The following is a description of a gene set: from publication Chen Y, Wang X (PMID 31504780) Mouse Gene Set: MIR_1955_3P studied in species Mus musculus Genes predicted to be targets of miRBase v22 microRNA mmu_miR_1955_3p in miRDB v6.0 with MirTarget v4 prediction scores > 80 (high confidence targets)., and this is the list of marker genes: Commd10, Tex16, Kctd8, Smarca1, Dazl, Abi3bp, Fam81a, Pld5, Satb2, Ap1s3, Mpc1, Nfkb1, Map6, Spata7, Npas3, Qsox1, Hnrnpl, Serinc5, Atxn2, Grk1, Slitrk6, Zfp953 (zinc finger protein 953), Tra2b, Gria3, Nr5a2, Reep3, 4930426D05Rik, Sec22b, Lhfpl3, Kdm6b, Cpeb4, Sos2, Npy6r, Obox3, Fam120a, Rslcan18, B3galt1, Elavl2, Prkcb, Zfp457, Adam30, Ncam2, Arf6 (ADP-ribosylation factor 6), Gpbp1l1, Tyms, Uevld